The following is a description of a gene set: The nucleus of either the ovum or the spermatozoon following fertilization. Thus, in the fertilized ovum, there are two pronuclei, one originating from the ovum, the other from the spermatozoon that brought about fertilization; they approach each other, but do not fuse until just before the first cleavage, when each pronucleus loses its membrane to release its contents. Mouse Gene Set: GOCC_PRONUCLEUS species: Mus musculus, and this is the list of marker genes: Rad50, Ezh2, Dppa3, Tcl1, Blm, Rif1, Ccna2, Hnrnpc, Taf1, Hnf1a, Cbx1, Stpg4, Hsf1, Akap8, Ncapd2, Aurka, Hnrnpl, Slc2a1, Mettl23, Tet3, Plcz1 (phospholipase C, zeta 1), Cenpf, Eed, Tbp